Given this list of marker genes Ccl5, Ccl3, Xcl1 (NCBI Gene Id 98422), Cxcl14, Ccl7, here is a description of the gene set: Any process that activates or increases the frequency, rate or extent of natural killer cell chemotaxis. Mouse Gene Set: GOBP_POSITIVE_REGULATION_OF_NATURAL_KILLER_CELL_CHEMOTAXIS studied in species Mus musculus